Given this list of marker genes Gsn, Cer1, Mapk8, Hspa8, Hmox1, Cyp1a2, Mapk9, Star, Cyp2a5, Cybb, Sox2, Mapk3, Slc11a1, Chuk, Daxx, Mapk1, Mt3, Jun, Hesx1, Akt1, Mmp9, Egfr, Mt2, Fos, Hsf1, Foxa2, Mt4, Slc39a8, Sumo1, Ogg1, Mt1, Abcb6, here is a description of the gene set: Any process that results in a change in state or activity of a cell (in terms of movement, secretion, enzyme production, gene expression, etc.) as a result of a cadmium (Cd) ion stimulus. studied in species Mus musculus Mouse Gene Set: GOBP_CELLULAR_RESPONSE_TO_CADMIUM_ION